The following is a description of a gene set: Human Gene Set: MENON_FETAL_KIDNEY_6_COLLECTING_DUCT_CELLS from publication Menon R, Otto EA, Kokoruda A, Zhou J, Zhang Z, Yoon E, Chen YC, Troyanskaya O, Spence JR, Kretzler M, Cebrián C (PMID 30166318) studied in species Homo sapiens, and this is the list of marker genes: EFNB2, ELF5, COA3, CTSH, LIMCH1, NPNT (NCBI Gene Id 255743), LHX1, SAT1, BCAT1, CLU, ENO1, TSTD1, ARPC2, RTN4, CD2AP, MECOM, MAL2, CD9, GSTM3, FOS, ARL4C, CLDN4, MYO6, KRT8, PPDPF, IQGAP1, EMX2, DMKN, MRPL33, ID1, GATA3, JUN, RDH10, S100A11, IVNS1ABP, HDAC1, KRT19, TSC22D1, TMSB4XP8, S100A10, KRT18, CHD3, EPCAM, KLF6, EMX2OS, IER2, ECHDC2, HSPB1, MAL, TBX3, MYL12A, NEDD4L, AHI1, LRRFIP1, AKR1B1, S100A6, LRPAP1, TCEAL9, AGR2, EIF1, PTPRF, ANXA2, SPINT2, B2M, MAP4, PDHA1, WFDC2, HOXB7, COBLL1, CALM1, BTG2, SCOC (short coiled-coil protein), PTBP3, RALBP1, EGR1, SCIN, CLTC, EZR, PAX8, GSTP1, ALDH1A1, PTPN13, CYB5A, ASAH1 (N-acylsphingosine amidohydrolase 1), ZFP36L1, RAB11FIP2, CCDC198, METAP2, STC1, TMSB4X, SPATS2L, AFDN, ADH1C, MGST3